The following is a description of a gene set: Human Gene Set: GOMF_INTRAMOLECULAR_OXIDOREDUCTASE_ACTIVITY_INTERCONVERTING_KETO_AND_ENOL_GROUPS studied in species Homo sapiens Catalysis of an oxidation-reduction (redox) reaction in which the hydrogen donor and acceptor, which is a keto- or an enol-group, are the same molecule, and no oxidized product appears., and this is the list of marker genes: DDT, FAHD2B, FAHD1, MIF, FAHD2A, DDTL